The following is a description of a gene set: Human Gene Set: HP_PROMINENT_STERNUM Prominent sternum species: Homo sapiens, and this is the list of marker genes: PRKG2, DLK1, RMRP, BMP2, ZFPM2, ARSB, DYM, MEG3, WNT7A, AIFM1, GALNS, GLB1, GATA6, RTL1, LONP1